The following is a description of a gene set: Eicosanoids species: Homo sapiens Human Gene Set: REACTOME_EICOSANOIDS, and this is the list of marker genes: CYP8B1, CYP4A11, PTGIS, CYP4A22 (cytochrome P450 family 4 subfamily A member 22), CYP4B1, CYP4F8, CYP4F2, CYP4F3, CYP4F11, CYP4F22, CYP4F12, TBXAS1